The following is a description of a gene set: Human Gene Set: GOBP_REGULATION_OF_LEUKOCYTE_DIFFERENTIATION Any process that modulates the frequency, rate or extent of leukocyte differentiation. studied in species Homo sapiens, and this is the list of marker genes: PHF10, FSHB, TAOK3, CARD11, NRARP, CTNNB1, TGFB1, LTF, LILRB3, GPR55, POU4F2, AXL, PGLYRP3, PRDM1, NCKAP1L, IL4R, PPP2R3C, KAT2A (NCBI Gene Id 2648), FOXN1, IL12B, TLR3, IFNL1, TM4SF19, DUSP10, SLC46A2, IL4, LILRB1, TNFAIP6, SHB, FANCD2, RPTOR, CREB1, ZEB1, HMGB3, TCF7, CD28, IL10, MMP14, IRF1, IL2RA, CEBPB, TGFBR2, PCID2, NF1, TNFSF9, IL21, C1QC, SART1, LGALS9, MAFB, BRD7, ZFP36L2, SOD1, EEIG1, VNN1 (vanin 1), NOTCH2, IFNA2, INHA, IFNB1, PRDM16, SMARCC1, BTK, OPA1, LGALS1, ZBTB46, IRF7, IL18, RUNX3, SMARCE1, BATF, ADIPOQ, RIPK1, INHBA, GLI2, TOB2, HLA-B, RARA, NKAP, SHH, MTOR, FGL2, TBX21, IL5, CD46, RNF41, HSF1, INPP5D, IL2RG, TREM2, NEDD9, RC3H1, AMBRA1, IL12RB1 (interleukin 12 receptor subunit beta 1), SOX4, LAG3, GLI3, SMARCD2, ACTL6B, PTPN6, SOCS1, AP3D1, SPINK5, MIR223, SOCS5, SMARCB1, ITPKB, PGLYRP1, METTL3 (NCBI Gene Id 95719), STAT5A, GPR137B, BMP4, TMEM176A, CCR1, EVI2B, CAMK4, GPR137, APCS, RC3H2, SFRP1, ERFE, PIAS3 (protein inhibitor of activated STAT 3), PTPN2 (protein tyrosine phosphatase non-receptor type 2), VSIR (NCBI Gene Id 64115), FOS, CASP8, ASCL2, KAT5, SLC4A2 (solute carrier family 4 member 2), CTNNBIP1, IL23R, ID2, TOX, IL15RA (NCBI Gene Id 3601), CLPTM1, PRKCZ, ZMIZ1 (NCBI Gene Id 57178), SOX13, FES, ABL1, MITF, MALT1, DDRGK1, SOS2, MDK, CD74, ZNF683, FSHR, CD83, FOXJ1, JUNB, ERBB2, GPR65, FADD, DCSTAMP, MIR30B, CYP26B1, ZFP36L1, ZBTB7B, NDFIP1, CCR2, PPARGC1B, GAS6, CD86, CCL19, ADAM8, LILRB4, SYK, ACIN1, BGLAP, ACTL6A, SOX12, KCNK18, SLAMF8, HOXA7, KITLG, LIF (NCBI Gene Id 3976), CD4, IL20 (interleukin 20), PNP, CEACAM1, LOXL3, IL2, HCLS1, RHOH, MIR21 (NCBI Gene Id 406991), FSTL3, SMARCA4, SLC9B2, SMAD7, MIR486-1, ADA, IKZF3, PTPRC, ZBTB1, BTN2A2, BCL6, HMGB1, TRIB1, OCSTAMP, AP3B1, XRCC6, TMEM64, BRD2, TNFSF11, IAPP, FOXP3, TNFSF18, GATA2, ARID2, DTX1, TMEM178A, LCK, BAD, CARTPT, GPR68, LRRC17, NLRP3, HLA-DOA, FBXW7, TLR9, BRD4, CD2 (CD2 molecule), FBXO7, PGLYRP2, IL27, SASH3 (SAM and SH3 domain containing 3), FOXO3, PF4, CTLA4, IL17A, LILRB2, TFE3, CDKN2A, GATA3, IL36B, NFAM1, CSF1, IL23A, FOXP1, TESC, CLEC4G (NCBI Gene Id 339390), PBRM1, SPI1, EGR3, JAK3, CUL4A, IL1RL2, SOS1, CCL3, CALCA, CD80, PRXL2A, TRAF6, SMARCA2, NFKBID, CBFB, HLX, FCRL3, IL15, SH3RF1, ZBTB16, RASGRP1, CDK6, WNT10B, PSG9, ACTB, TNFSF4, RAG2, NFKBIZ, PLA2G3, RIPK2, PIK3R6, UBASH3B, RAG1, POU4F1, MIR145, FANCA, TAL1, EP300, BRAF, DROSHA, PRELID1, TCTA, MIR17HG, PRKCA, IHH, CD101, TNFRSF11A, TNFRSF11B, CRTAM, IL7, PRDX2, CLEC12A, ARID1A, PIK3R1, CR1, ANXA1, MYC, RUNX1, ARID1B, MIR125B1, XBP1, TNF, SMARCC2, PRKDC, LEF1, CD27, RASSF2, AGER, STAT5B, TYROBP, CYLD, FBN1, ZC3H12A, TLR4, ZNF675, KLF10, HLA-DRA, IL7R, ZAP70, RHOA, SMARCD1, TESPA1, SMARCD3, LYN, CD69, IL34, HAX1, TMEM131L, IL4I1, PPP3CA, CLDN18, TMEM176B, ZC3H8, HLA-DRB1, HLA-G, FCGR2B, KLHL25, PCK1, RB1, LGALS3, IRF4, IFNG, QKI, ZFPM1